Given this list of marker genes MT-ND1, MT-ATP6, OPA1, MT-ND4L, MT-ND4, MT-ND6, NDUFS2, MT-CO1, MT-CYB, MT-CO3 (mitochondrially encoded cytochrome c oxidase III), MT-ND2 (NCBI Gene Id 4536), MT-ND5, DNAJC30, here is a description of the gene set: A scotoma (area of diminished vision within the visual field) located between the central point of fixation and the blind spot with a roughly horizontal oval shape. studied in species Homo sapiens Centrocecal scotoma Human Gene Set: HP_CENTROCECAL_SCOTOMA